The following is a description of a gene set: Any process that results in a change in state or activity of a cell (in terms of movement, secretion, enzyme production, gene expression, etc.) as a result of an electromagnetic radiation stimulus. Electromagnetic radiation is a propagating wave in space with electric and magnetic components. These components oscillate at right angles to each other and to the direction of propagation. Mouse Gene Set: GOBP_CELLULAR_RESPONSE_TO_RADIATION species: Mus musculus, and this is the list of marker genes: Trpm1, Mmp1b, Rrh, Crb1, Rad9b, Lig4, Rnf4, Nedd4 (neural precursor cell expressed, developmentally down-regulated 4), Nsmce3, Npm1, Trp53inp1, Hyal1, Rhno1, Crebbp, Atr, Rhbdd1, Opn1mw (NCBI Gene Id 20164), Ints7, Ruvbl2, Rp1, Net1, Actr5, Hsf1, Rad23b, Hyal3, Ifi208, Timp1, Ddias, Pik3r1, Grk1, Hus1, Xpc, Sfrp2, Prap1, Tmem161a, Smpd1, Snai2, Casp9, Bmf, Aqp1, Stk11, Bard1, Mme, Slc24a4, Gata3 (GATA binding protein 3), Rgr, Rhob (ras homolog family member B), Opn5, Bak1, Ppid, Tmem109, Ifi203, Rgs9, Opn1sw, Tlk2 (tousled-like kinase 2 (Arabidopsis)), Ddb1, Trex1, Egr1, Mtch2 (mitochondrial carrier 2), Ifi206, Fbxo4, Yap1 (NCBI Gene Id 22601), Pierce1, Sirt1, Ercc1, Atm (NCBI Gene Id 77416), Chek2, Cul4b, Babam2, Rpgr, Mapk14, Tank, Ifi214, Ccnd2, Mmp1a, Gpr88, Aipl1, Poli, Tgfb1, Agap3, Aurkb, Eef1d, Usp28, Pcna, Rad1, Akt2, Mapk11, Ptprk, Crip1, Opn3, Swi5, Mapk9, Ifi203-ps, Rho, Cul4a, Ect2, Xpa, Hras, N4bp1, Kdm4d, Mmp2, Brca2, Mmp3, Rad51ap1, Ifi213, Mapk13, Cdkn2a, Grb2, Rad23a, Xrcc6, Mettl3 (methyltransferase 3, N6-adenosine-methyltransferase complex catalytic subunit, NCBI Gene Id 80554), Eif2ak4, Ifi207, Nipbl, Polh, Rad9a, Elk1, Sfrp1, Nlrp1a, H2ac25, Mmp9, Pold3, Mndal, Brcc3dc, Gpr52, Triap1, Prkcd, Fignl1, Hyal2, Ddb2, H2aj, Ino80, Kcne1, Gadd45a, Nscme3l, Ei24, Bax, Sde2, Blm, Clock, Pcp2, Tspyl5, Ep300, Bcl2l1, Nucks1, Rbx1, Xrcc5, Zmpste24, Rbx1-ps, Bbc3, Cers1, Trp53, Brcc3 (NCBI Gene Id 210766), Nfatc4, Dhx36, Mdm2, Parp1, Rad51 (NCBI Gene Id 99282), Gnat1, H2ax (NCBI Gene Id 15270), Cdc25a, Tnf, Itgb6, Pold1, Wrn, Cryab, Noc2l, Gnb5, Pola1, Rpl26, Yy1, Cdkn1a (NCBI Gene Id 12575), Nlrp1b, Mc1r, Tnks1bp1, Gtf2h5, Map3k20, Pbk, Trp53bp1, Eif2s1, Spidr, Rnf168, Opn4, Brca1, Ercc4 (excision repair cross-complementing rodent repair deficiency, complementation group 4), Kdm1a, Zbtb1, Mfap4, Fbxw7, Cops9, Polk, Ifi209